Given this list of marker genes AW112010, Ifi30, Flot1, Psmb9, Scgb1a1, Il21r, Ciita, here is a description of the gene set: Mouse Gene Set: TABULA_MURIS_SENIS_LUNG_MYELOID_DENDRITIC_CELL_AGEING from publication Tabula Muris Consortium (PMID 32669714) species: Mus musculus